Given this list of marker genes HBA1, RBM38 (RNA binding motif protein 38), TMCC2, SPECC1, PPME1, CAT, SHCBP1, HBM, RHAG, XPO7, TRIM58 (tripartite motif containing 58), SLC38A5, MAP2K3, ABCB10, ACSL6, SLC25A39, CDC20, HMBS, TRIM10, SPTA1 (NCBI Gene Id 6708), RHCE, SLC25A21, MINPP1, E2F2, SNCA, AHSP, ABCC13, KEL, DLGAP5, SPTB, ART4, C17orf99, LINC02506, SLC14A1, CDKN2D, ABCA7, TSPAN32, RIPOR3, GYPB, CDC27, HBG1, SEC14L4, TLCD4, GYPE, HBG2, SLC4A1, CPOX, HBZ, DEPDC1B, CR1L, HEMGN, UROD, YOD1, MYL4, NPL, TF, FAM117A, RNF224 (ring finger protein 224), RGS6, NFE2, MARCHF2, ANK1, FAM83D, USP15, EPB42, SNX22, GYPA, FECH, TENT5C, CROCCP2, SPC25, MXD3, TRAK2, INCENP, BLVRB, STRADB, KLF1 (KLF transcription factor 1), BIRC5, RILP, GCLC, OSBP2, EIF2AK1, H1-2 (NCBI Gene Id 3006), KIF15, HBB, RHD, ERMAP, UBE2O, CDCA5 (NCBI Gene Id 256676), RFESD, DCAF12, ALAD, SCARNA22, SLC25A37, PARPBP, UROS, ALAS2, ENSG00000260592, USP32, HBA2, TUBB1 (tubulin beta 1 class VI), here is a description of the gene set: Human Gene Set: DESCARTES_FETAL_STOMACH_ERYTHROBLASTS Marker genes curated from the annotated cluster as represented in the Descartes Human Gene Expression During Development database. from publication Cao J, O'Day DR, Pliner HA, Kingsley PD, Deng M, Daza RM, Zager MA, Aldinger KA, Blecher-Gonen R, Zhang F, Spielmann M, Palis J, Doherty D, Steemers FJ, Glass IA, Trapnell C, Shendure J (PMID 33184181) The gene expression program underlying the specification of human cell types is of fundamental interest. The study authors generated human cell atlases of gene expression and chromatin accessibility in fetal tissues. For gene expression, the study authors applied three-level combinatorial indexing to >110 samples representing 15 organs, ultimately profiling ~4 million single cells. The study authors leveraged the literature and other atlases to identify and annotate hundreds of cell types and subtypes, both within and across tissues. Our analyses focused on organ-specific specializations of broadly distributed cell types (such as blood, endothelial, and epithelial), sites of fetal erythropoiesis (which notably included the adrenal gland), and integration with mouse developmental atlases (such as conserved specification of blood cells). These data represent a rich resource for the exploration of in vivo human gene expression in diverse tissues and cell types. studied in species Homo sapiens